Given this list of marker genes MYCBP, CD9, PHC1, DPPA2, LIN28B, CXCL5, TINF2, GDF3, REXO1, PIWIL2, UTF1, DNMT3B, KLF5, MYBL2, LIN28A, SOX2, AKT3, GABRB3, GJA1, TTLL4 (NCBI Gene Id 9654), ZNF436, POU5F1, DPPA4, MYC, SALL2, POU6F1, RET, NANOG, ELOVL6, TERF1, PRRX1, RHOXF1, ZFP42, TEP1, PHTF2, HSPA4, KLF4, PROM1, DKK3, here is a description of the gene set: studied in species Homo sapiens from publication Conrad S, Renninger M, Hennenlotter J, Wiesner T, Just L, Bonin M, Aicher W, Bühring HJ, Mattheus U, Mack A, Wagner HJ, Minger S, Matzkies M, Reppel M, Hescheler J, Sievert KD, Stenzl A, Skutella T (PMID 18849962) Human primordial germ cells and mouse neonatal and adult germline stem cells are pluripotent and show similar properties to embryonic stem cells. Here we report the successful establishment of human adult germline stem cells derived from spermatogonial cells of adult human testis. Cellular and molecular characterization of these cells revealed many similarities to human embryonic stem cells, and the germline stem cells produced teratomas after transplantation into immunodeficient mice. The human adult germline stem cells differentiated into various types of somatic cells of all three germ layers when grown under conditions used to induce the differentiation of human embryonic stem cells. We conclude that the generation of human adult germline stem cells from testicular biopsies may provide simple and non-controversial access to individual cell-based therapy without the ethical and immunological problems associated with human embryonic stem cells. Supplementary Table 2. Genelist comparing microarray expression profiles of spermatogonial cells, haGSCs and hES (H1) cells. Examples of expression rates of different hES cell enriched and germ cell specific genes, surface markers for germ cell selection and signal transduction in all three cell types (spermatogonial cells = SC). Human Gene Set: CONRAD_STEM_CELL